Given this list of marker genes RFX5, RFXANK (regulatory factor X associated ankyrin containing protein), JAK3 (NCBI Gene Id 3718), AK2, ADA, CIITA, RFXAP, here is a description of the gene set: species: Homo sapiens Human Gene Set: HP_ABSENT_CELLULAR_IMMUNITY Complete inability of T cells to perform their functions in cell-mediated immunity. Absent cellular immunity